The following is a description of a gene set: studied in species Mus musculus Mouse Gene Set: YAO_AJ_MOUSE_LUNG_TUMOR_PROGRESSION_DIFFERENT_ADENOMA_DN Genes detected by RT-PCR showing different changes in lung adenomas and lung adenocarcinomas. Tissue is from lung adenoma from female A/J mice. from publication Yao R, Wang Y, Lubet RA, You M (PMID 12173053) Female A/J mice received a single i.p. injection of N-methylnitrosourea (MNU) in acidified saline (pH 5.0) at a dose of 50 mg/kg body weight., and this is the list of marker genes: Tgfb2, Pdgfa, Igfbp6, Bax, Kdr, Abi1 (abl interactor 1)